The following is a description of a gene set: Human Gene Set: STAMBOLSKY_BOUND_BY_MUTATED_TP53 The p53 gene is mutated in many human tumors. Cells of such tumors often contain abundant mutant p53 (mutp53) protein, which may contribute actively to tumor progression via a gain-of-function mechanism. We applied ChIP-on-chip analysis and identified the vitamin D receptor (VDR) response element as overrepresented in promoter sequences bound by mutp53. We report that mutp53 can interact functionally and physically with VDR. Mutp53 is recruited to VDR-regulated genes and modulates their expression, augmenting the transactivation of some genes and relieving the repression of others. Furthermore, mutp53 increases the nuclear accumulation of VDR. Importantly, mutp53 converts vitamin D into an antiapoptotic agent. Thus, p53 status can determine the biological impact of vitamin D on tumor cells. Gene promoters preferentially bound by a mutated form of TP53 in SKBR3 cells (breast cancer). species: Homo sapiens from publication Stambolsky P, Tabach Y, Fontemaggi G, Weisz L, Maor-Aloni R, Siegfried Z, Shiff I, Kogan I, Shay M, Kalo E, Blandino G, Simon I, Oren M, Rotter V (PMID 20227041), and this is the list of marker genes: FRAS1, TUBA1C, ACTR10, MAGEH1, PCDHA7, EEF1AKMT4-ECE2, MARK2, ECRG4, NFS1, LIG1, VIPR2, MRTFB, SKP2, CPT1B, GHR, STATH, SPRING1 (SREBF pathway regulator in golgi 1), KLF10